Given this list of marker genes COL6A2, COL1A1, CTSC, SLC39A13 (solute carrier family 39 member 13), COL3A1 (NCBI Gene Id 1281), COL5A2, COL5A1, COL12A1, COL6A3 (collagen type VI alpha 3 chain), COL6A1, here is a description of the gene set: Cigarette-paper scars Human Gene Set: HP_CIGARETTE_PAPER_SCARS Thin (atrophic) and wide scars. species: Homo sapiens